The following is a description of a gene set: species: Mus musculus The process that results in increased metabolic rate in tissues of an organism. It is triggered by the detection of dietary excess. This process is achieved via signaling in the sympathetic nervous system. Mouse Gene Set: GOBP_DIET_INDUCED_THERMOGENESIS, and this is the list of marker genes: Ucp1, Oma1, Adrb3, Mc4r, Trpv1 (transient receptor potential cation channel, subfamily V, member 1), Sctr, Clic5, Sorl1, Adrb2, Gpr39, Pparg, Appl2, Adrb1, Sct, Trpv4, Bmp8b